Given this list of marker genes H2-Q4, H60c, Ptprc (NCBI Gene Id 19264), Tap2, H2-T15, Nectin2, Cd1d2, Il7r, H2-M2, Stx7, H2-Ea, Hspa8, H2-M10.3, H2-M10.4, H2-Q1, H2-T5, Pnp (NCBI Gene Id 18950), H2-M3, H2-T13, H2-M10.6, H2-M10.5, Raet1e, Nckap1l, Raet1d, H2-M11, Klrd1, Ulbp1, Ager, H2-D1, Il12b, H2-M10.2, Slc22a13, H2-M5, Il23a, Pvr, H2-T23, Fadd, B2m, Ppp3cb, H60b, H2-K1, H2-Q6, Il12a, H2-T22, Muc4, P2rx7, Cyrib, Cd1d1, H2-M1, H2-M9, H2-Q10, Ripk3, H2-Q7, Azgp1, H2-M10.1, 2410137M14Rik, H2-T24, Ceacam1, H2-T3, H2-Q2, Mr1, Xcl1, here is a description of the gene set: species: Mus musculus Any process that modulates the frequency, rate, or extent of T cell mediated cytotoxicity. Mouse Gene Set: GOBP_REGULATION_OF_T_CELL_MEDIATED_CYTOTOXICITY